The following is a description of a gene set: Mouse Gene Set: GOBP_SENSORY_SYSTEM_DEVELOPMENT studied in species Mus musculus The process whose specific outcome is the progression of a sensory system over time from its formation to the mature structure., and this is the list of marker genes: Gnb1, Tfap2a, Agtpbp1, Wdpcp, Bbs10, Bcl11b, Vhl, Ints15, Rxra, Zhx2, Spred1, Tspan12, Sox9, Bax, Ninj1, Gja1 (gap junction protein, alpha 1), Samd7 (sterile alpha motif domain containing 7), Foxc1, Bhlhe22, Mir27b, Megf11, Rbp4, Twist1, Nr2e3, Cryga, Stau2, Ulk1, Tsku, Notch2, Barhl2, Notch1, Sall2, Atoh7, Shh, Acvrl1, Isl1, Nf2, Neurod4, Rrm1, Bsg, Tgfbr2, Slc38a8, Pax2, Lamb2, Sox12, Pygo2, Tgfbr1, Meis2 (Meis homeobox 2), Angptl7, Vsx2, Pdgfb, Crygf, Apc, Six5, Col4a1, Abi2, Cdkn1c, Casz1, Efemp1, Phox2b, Crx, Foxl2, Aldh1a1, Atp8a2, Arhgap35, Inhbb, Neurod1, Trpm1, Gli3, Flt1, Ptprm, Crygn, Fgf2, Ift88, Atf6, Dcx, Nectin3, Pdgfra, Nfia, Krtap21-1, Alms1, Pitx3, Ret, Maf, Col8a2, Mir183, Bak1, Miat, Crybb3, Pax4 (paired box 4), Ulk2, Osr2, Hpca, Bloc1s3, Fasl, Cntf, Rho, Rhoj, Cryab, Crb2, Smarcd3, Nphp4, Lama1, Twsg1, Smad3, Mfsd8 (NCBI Gene Id 99720), Spry2, Nes, Ski, Hif1a, Nf1, Arl6, Nfib, Pbx2, Bfsp1 (beaded filament structural protein 1, in lens-CP94), Vax2os, Pde6c, Cacna1c, Ttll5, Tgfb2 (transforming growth factor, beta 2), Tmod1, Prdm1, Cryba2, Ttc8, Pbx1, Gja8, Gje1, Mab21l1, Slc17a6, Mfsd2a, Ift122, Wt1, Uchl3, Mir182, Poc5 (POC5 centriolar protein), Slc7a11, Nrl, Bhlhe23, Kdm5b, Dlg1, Tfap2b, Rara, Prkci, Crygc, Frem2, Lmx1b, Casp2, Cyp1a1, Hsf4, Irx5, Prss56, Bfsp2, Mir124a-2, Arsg, Rpgr, Th, Dtnbp1, Spry1, Tbc1d20, Rpe65, Krt12, Slc6a3, Pbx4, Tenm3, Cln8, Crybb2, Grhl2, Dscam, Cryba4 (NCBI Gene Id 12959), Vstm4, Mir218-2, Mitf, Dlx2, Ahr, Traf3ip1, Tbc1d32, Dll1, Ring1, Irx6, Hipk2, Gngt1 (guanine nucleotide binding protein (G protein), gamma transducing activity polypeptide 1), Rom1, Fbn2, Dio3, Rcn1, Hmgb1, Slc44a4 (NCBI Gene Id 70129), Psen1, Nrp1, Foxe3, Pde6a, Fgf9, Skil, Ntrk2, Gnat1, Smarca4, Crygb, Sdk2, Scaper, Mertk, Ctns, Rax, C3, Nr2e1, Chd7, Ush1c, Gata3, Bbs1, Abcb5, Crygs, Pcnt, Impg2, Aldh1a2, Kdm2b, Prickle1, Pou2f1, Kera, Xrn2, Tbx2, Usp45, Calb1, Myf5, Ndp, Tgif1, Hcn1, Tmem135, Spred2, Scrib, Opn5, Grk1, Bmp7, Foxf2, Cfh, Cc2d2a, Rorb, Grm6, Prom1, Dram2, Pxdn, Rdh10, Pknox1, Plaat3, Tcirg1, Mip, Pitx2, Tmem231, Fos, Slc25a25, Nfix, Pde6b, Pou4f2, Ikzf1, Slc39a5, Cdkn1b, Slc1a1, Cep290, Mfap2, Jun, Adamts9, Pdgfrb, Cacna1s, Lim2, Cryba1, Mir24-2, Hes5, Bmpr2, Aqp1, Rp1l1, Large1, Acvr2b, Ahi1, Bcl2, Gpm6a, Rab3gap1, Rpl24, B9d1, Sox8, Cyp1b1, P2ry12, Mfap5, Bmp4 (bone morphogenetic protein 4), Pfdn5, Dll4 (NCBI Gene Id 54485), Gnat2 (G protein subunit alpha transducin 2), Cited2, Dlx1, Rarb, Col8a1, Ift140 (intraflagellar transport 140), Mfrp, Stra6, Zfp513, Limk2, Foxc2, Kmt2c, Atp2b4, Ift172, Plaat1, Dzank1, Thrb, Bmpr1b, Tdrd7 (tudor domain containing 7), Max, Yy1 (NCBI Gene Id 22632), Sp3, Rab18, Arhgef15 (NCBI Gene Id 442801), Rdh13 (NCBI Gene Id 71482), Ptn, Lpcat1, Grhl3, Fkbp8, Vax1 (NCBI Gene Id 22326), Ctnnb1, Grn, Mir27a, Frs2, Smoc1, Six3, Ephb2, Hps1, Pds5b, Fgfr3, Ntrk3, Sh3pxd2b, Lamc3, Mir96, Olfm3, Mterf4, Casp6, Cryge, Slc4a5, Bcar3, Twist2, Otx2, Fkrp, Ptf1a, Rpgrip1, Ache, Fgf10, Serpinf1 (NCBI Gene Id 20317), Wdr19, Slc4a7, Hdac2, Sp1, Gsdma3, Clcn2, Gdf11, Foxn4, Spred3, Arid1a, Slitrk6, Lrp6, Bmp6, Gdf3, C1qa, Jag1, Pax6, Chrdl1, Mir23a, Cdk20, Actl6a, Bbs4, Sox4, Tub, Slc17a8, Man2a1, Fscn2, Stat3, Pou4f1, Adamts18, Hdac1, Foxp2, Jmjd6 (NCBI Gene Id 70547), Crygd, Ihh, Sdk1, Crybb1, Bdnf, Srf, Rd3, Ephb1, Fgfr2, Vsx1, Crybg3, Crb1, Sox11, Inhba, Mir23b (microRNA 23b), Mir24-1, Sipa1l3, Rp1, Cldn19, Tgfb1, Hipk1, Cfd (complement factor D), Klf4, Ftx, Pbx3, Six6, Tgif2 (NCBI Gene Id 97009), Rs1, Hesx1, Samd11, Cnga3, Nhs, Nipbl, Col5a2, Myh10, Fbn1, Map3k1, Lif, Zeb1, Drd2, Vim, Hes1, Cryaa, Vax2, Unc45b, Cdon, Hmgn1 (high mobility group nucleosomal binding domain 1), Ppp2r3a, Gas1, Lhx1 (LIM homeobox protein 1), Mab21l2, Itgam, Lctl, Gabrr2, Sox2, Zeb2, Tmem215, Smg9, Sco2, Fjx1, Opn4, Cacna1f, Grcc10, Meis1, Sox1 (SRY (sex determining region Y)-box 1), Med1, Nectin1, Phactr4, Rpgrip1l, Ppp1r13l, Clic4, Cabp4, Mfn2, Per1, Elp6, Tulp1, Egfr, Vegfa, Fzd4, Pds5a, Kdr, Prph2, Tmem132e, Bbs7, Meis3, Epha2, Fat3, Celf4, Aqp5, Birc7, B3glct, Myom1, Nphp1, Shroom2, Tulp3, Mdm1, Zdhhc16, Fzd5, Naglu, Mir124a-1, Mir218-1, Rarg, Gpd2, Lrp5, Atf4, Fat1, Prox1, Sos1, Col5a1, Fzr1, Lhx2, Aldh1a3, Thy1